Given this list of marker genes ITCH, GPR61, FFAR4, CREB1, ARRDC1, GPR62 (NCBI Gene Id 118442), SLC9A5, DRD1, ARRB1, CHRM2, GPR135, here is a description of the gene set: Binding to a member of the arrestin family, proteins involved in agonist-mediated desensitization of G protein-coupled receptors. species: Homo sapiens Human Gene Set: GOMF_ARRESTIN_FAMILY_PROTEIN_BINDING